Given this list of marker genes PLEKHG1, PLCD4, RCC1L, ADRA2A, GDPGP1, ARHGEF2, DEF6, TBXA2R, FBXO8, RIC8A, PSD3, ARHGEF19, HERC1, PSD4, ARHGEF15, SOS1, SBF1, DENND2B, EGF, ARHGEF3, PCP2, ARHGEF5, IQSEC3, RASGRP3, LAMTOR1, DOCK9, RAPGEF1, CCDC88C, MYCBP2, AKAP13, RASGEF1B, ITSN1, SERGEF, DNMBP, OBSCN (NCBI Gene Id 84033), RHOF, RASGRP1, C9orf72, RHOU, EIF2B3, BCAR3, RABGEF1, DENND3, ECT2L, RASGRF2, PLEKHG6, EEF1D, DOCK3, RGL4, TRIO, EIF2B4, HERC2, DENND5A, FARP1, HPS4, RGL2, ARHGEF28, RAP1A, DOCK2, SH3BP5, RAPGEF5, EEF1B2, RAB3GAP2 (NCBI Gene Id 26114), ARHGEF18, DENND2C, FGD3, GAPVD1, IQSEC1, ADRA2C (NCBI Gene Id 152), DENND4C (DENN domain containing 4C), FARP2, ARHGEF1, PSD2, ARHGEF4, DENND2D, EPS8L1, ALS2CL, DENND4B, RIN2, FGD1, ARHGEF10L, ARHGEF37, PLEKHG5, CYTH4, RAPGEF6, MCF2 (NCBI Gene Id 4168), ARHGEF6, VAV1, KIAA1755, ARHGEF33, TBC1D10A, RIN1, LAMTOR2, PTGIR, SOS2, ARHGEF25 (Rho guanine nucleotide exchange factor 25), PLEKHG7, EIF2B5, DOCK7, SPATA13, RAB3GAP1, RAPGEF4, CYTH1, PLEKHG4, CCDC88A, RASGRP4, DENND6A, ITSN2 (NCBI Gene Id 6454), FGD6, RGP1, GNA13, CYTH3, DOCK6, PLEKHG4B, P2RY12 (purinergic receptor P2Y12), PLCE1, DENND6B, RASGEF1A (RasGEF domain family member 1A), ARHGEF12, EPS8L3, RANBP10, PREX2, RCBTB2, VAV3, TIAM1, ANKRD27, RAB3IP, MCF2L, SBF2, DOCK10, GRIPAP1, RALGDS, MCF2L2, RPGR, ARHGEF38, MON1A, NGEF, IQSEC2, DENND5B, DENND2A, EIF2B2, ARHGEF26, FGD4, NET1, SWAP70, EPS8L2, RIN3, PSD, SH2D3C, LAMTOR3, ARHGEF11, SH3BP5L, DOCK4, DENND1A, DENND11, RINL, VAV2, LAMTOR4, KNDC1, RASGRP2, RIC1, CCZ1, RALGPS1, SMCR8, RASGRF1, RAB3IL1, ARHGEF7, DENND10, RIC8B, EIF2B1, ARHGEF9, SH2D3A, NUCB2, TAGAP, RHOD, RCC2, ARFGEF3, ARHGEF40, RGL3, RABIF, RAPGEF3, RALGPS2, BCR, ARHGEF17, SEC61B, RCC1, FRMD7, ELMO1, NUCB1 (NCBI Gene Id 4924), ARFGEF1, DENND1B, PLCG1, ARF4, KALRN, VPS9D1, RASGEF1C, LAMTOR5, PREB, TIAM2, DIS3, DOCK1, GCGR, ARHGEF16, THG1L, ARHGEF39, MADD, PLEKHG2, DOCK8, ALS2, RAP1GDS1, CYTH2, RGL1, PLEKHG3, WDR41, ARHGEF10, RAPGEFL1, FGD2, DOCK5 (dedicator of cytokinesis 5), FGD5, SLC38A9, ECT2, DEPTOR, ARFGEF2 (ADP ribosylation factor guanine nucleotide exchange factor 2), RAPGEF2, HPS1, DENND4A, ABR, RANGRF, DENND1C, PREX1, DOCK11, GBF1 (golgi brefeldin A resistant guanine nucleotide exchange factor 1), here is a description of the gene set: Human Gene Set: GOMF_GUANYL_NUCLEOTIDE_EXCHANGE_FACTOR_ACTIVITY studied in species Homo sapiens Stimulates the exchange of GDP to GTP on a signaling GTPase, changing its conformation to its active form. Guanine nucleotide exchange factors (GEFs) act by stimulating the release of guanosine diphosphate (GDP) to allow binding of guanosine triphosphate (GTP), which is more abundant in the cell under normal cellular physiological conditions.